The following is a description of a gene set: studied in species Mus musculus This event has been computationally inferred from an event that has been demonstrated in another species.<p>The inference is based on the homology mapping from PANTHER. Briefly, reactions for which all involved PhysicalEntities (in input, output and catalyst) have a mapped orthologue/paralogue (for complexes at least 75% of components must have a mapping) are inferred to the other species. Reactome Pathway: Circadian clock electronically inferred by orthology from the curated human pathway, and this is the list of marker genes: Ubb, Psmb4, Psmd13, Psmd12, Psma6, Psmb5, Psmc4, Psmb6, Psmc5, Psma5, Rps27a, Psma4, Psmd7, Psma2, Psma7, Psmb7, Psmc1, Psmc2, Psmd6, Per1, Psmd1, Psmc6, Per2, Psma3, Psmc3, Psma1